Given this list of marker genes AMACR, CDK5, KIF3C, FABP4, MDH1, CCT3, CTNNBIP1, GNG2 (NCBI Gene Id 54331), FUNDC1, MMP19, PRG4, CARMIL1, NCMAP, PRDX2 (NCBI Gene Id 7001), OAZ2, DNTTIP2, METRN, FCGRT, PRRT1 (NCBI Gene Id 80863), C1orf54, PTGS1, MPV17, RHOG, ABCC3, NCOA1, BDH1, NISCH (NCBI Gene Id 11188), UBE2B, LRRC40, CREBRF, UTRN, FABP5, TM4SF5, ST3GAL2, TP53INP1, SLC25A10, SIAE, SUOX, GRK5, DNAJC12, DBI, ATP5PB, TXNDC16, GSTT2, KLF2, NFS1, PLXNB2, ANKRD44, GREM2, ACADVL, EMC2, LIMA1, CSE1L, SMIM14, FXYD2, HSD11B1, LPGAT1, CLYBL, ADAM23, NDUFV3, PGAM1 (NCBI Gene Id 95038), VRK3, LPXN, DOK3, SNRK, DGUOK, KGD4, ZNF362, UVRAG, HLF, GLIPR1, ZFAND5, PHLDA1, PDHB, MMS19, DDT, WNT6, NDUFA4, GCLC, EBPL, SDHA, EMILIN1, AP2A2, SLC16A3, DNMT3L, VPS72, ACSF2, WBP11, HERC2, MUL1, SH2D1B, PECAM1, VAMP4, MTA3, BST1, ATP5MC2, SLC37A2, TGFBR2, GSTZ1, LAMP2, COL1A2, SLAIN2 (SLAIN motif family member 2), AOAH, SERINC4, DGKA, POMGNT1, SPIDR, HIF1A, OSGIN1, MAGED1, LTC4S, ALDOA, C5AR1, CYB5R1, TCEAL8, DALRD3, HLCS, MAD2L2, PNKP, CENPM, PIM2 (NCBI Gene Id 11040), ST6GAL1, CENPQ, TDP2, CDK5RAP1, KRT33B, SHD, PTPRS, NDUFB10, PGK1, SLC16A7, MBP, BPHL, SNTA1, NDUFS3, TTC3, KDM3B (lysine demethylase 3B), MORF4L1, FAM111A, GBA2, RPL28, MSRB2, NADK, PRXL2B, SOS1, TNFRSF21, CS, RPL22L1, FNBP1, ANAPC5, CXCL6, TMEM126A, CNTFR, TMEM205, CROT, NR1H2, TMEM134, MXI1, SIN3A, HDAC5, AP1S1, TAL2, MCM9, CYB5A, DNPEP, BACH2, GLRX, VNN2, ETFRF1, IGBP1, CAPZA3, NEMF, KIAA1143, P2RX3, GPSM3, STAT4, BSCL2 (BSCL2 lipid droplet biogenesis associated, seipin), PGM2, PRKCB (protein kinase C beta), CALCRL, IFT80, MRPL38, TNPO2, VPS28, MAPK11, TSPAN13, MRAS, LRRK2, MYEF2, PDE4B, VILL, ENPP2, HDAC6, UQCRC2, PTPRK, NDUFA6, GALNT11 (polypeptide N-acetylgalactosaminyltransferase 11), SP3, SESN3, MARCO, here is a description of the gene set: Human Gene Set: GSE17721_12H_VS_24H_PAM3CSK4_BMDC_DN studied in species Homo sapiens Genes down-regulated in comparison of dendritic cells (DC) stimulated with Pam3Csk4 (TLR1/2 agonist) at 12 h versus those stimulated with Pam3Csk4 (TLR1/2 agonist) at 24 h. mouse primary BMDCs were stimulated with tlr ligands and gene expression changes were profiled on Affymetrix arrays from publication Amit I, Garber M, Chevrier N, Leite AP, Donner Y, Eisenhaure T, Guttman M, Grenier JK, Li W, Zuk O, Schubert LA, Birditt B, Shay T, Goren A, Zhang X, Smith Z, Deering R, McDonald RC, Cabili M, Bernstein BE, Rinn JL, Meissner A, Root DE, Hacohen N, Regev A (PMID 19729616)